The following is a description of a gene set: The chemical reactions and pathways resulting in the formation of phosphatidylinositol, any glycophospholipid in which the sn-glycerol 3-phosphate residue is esterified to the 1-hydroxyl group of 1D-myo-inositol. Human Gene Set: GOBP_PHOSPHATIDYLINOSITOL_BIOSYNTHETIC_PROCESS species: Homo sapiens, and this is the list of marker genes: IP6K2, PIGA, PIK3C2A, PDGFA (NCBI Gene Id 5154), SLC30A5 (solute carrier family 30 member 5, NCBI Gene Id 79021), BECN1, PIGT, PTPRQ, PGAP3, PI4K2B, BPNT2, PI4KB (NCBI Gene Id 5298), PIK3R4, MTMR4, PI4K2A, PITPNM2 (phosphatidylinositol transfer protein membrane associated 2), INPP4B, SYNJ1 (synaptojanin 1), PIP5K1C, PIGZ, PI4KA, PIP4K2C, PIGO, PIGG, BMX, TTC7B, PIPSL, PIP4K2B, PIP5K1B, MTM1, INPP5E, PIGF, PIGH, ITPKA, INPP4A, DPM2, TMEM150A, PIP4K2A, MTMR6, PIK3CG, PI4KAP2, PTEN (NCBI Gene Id 8037), GPAA1, PIGY, INPP5F, MBOAT7, PITPNM1, PIGV, HTR2C, PIK3CD, INPP5J, MTMR1, ATG14, INPP1, PIGK, SACM1L, FIG4, BPNT1, PIK3C2G, INPP5D, PLCG2, PIGM, CDIPT, HYCC2, PIK3C3, SYNJ2, DPM1, PIGC, DPM3, PIGQ, PIGN, HYCC1, UVRAG, ITPKB, PGAP1, HTR2B, PIGB, OCRL, EFR3A, SH3YL1, PDGFB, PIK3R3, VAC14, MPPE1, PIGP, IP6K3, EFR3B, PIP5KL1, DGKE, PIGX, PIKFYVE, INPP5K, PIK3R1, PIK3CA, PIK3C2B, INPPL1, PITPNM3, PIGL, PIGW, TPTE2, CDS1, IP6K1, PIGU, MTMR14, PIGS, CWH43, PGAP2, IMPA1, HTR2A, MTMR7, MTMR2, PIK3CB, PGAP4, PIP5K1A, IMPA2, MTMR3, SMG1, ITPKC, ATM, TTC7A